Given this list of marker genes Akt1, Ddrgk1, Cx3cr1, Erc1, Tlr4, Tlr7, Chuk, Ikbkb, Saa3, Cx3cl1, Map3k7 (NCBI Gene Id 93774), Tnf, Tlr2, Tlr3, Usp25, here is a description of the gene set: The process of introducing a phosphate group into an inhibitor of kappa B (I-kappaB) protein. Phosphorylation of I-kappaB targets I-kappaB for ubiquitination and proteasomal degradation, thus releasing bound NF-kappaB dimers, which can translocate to the nucleus to bind DNA and regulate transcription. studied in species Mus musculus Mouse Gene Set: GOBP_I_KAPPAB_PHOSPHORYLATION